The following is a description of a gene set: Mouse Gene Set: chr18B3 species: Mus musculus, and this is the list of marker genes: Kcnn2, Gm31907, Pcdhgb7, Pcdh1, Gm50410, Ythdc2, Pcdhb12, Spink6, Gm31087, Gpr151, Myot, Pcdhgc4, Pou4f3, Rps19-ps13, 1700086O06Rik, Spink11, Gm18371, Grxcr2, Cstdc7, Plac8l1, 4933407I08Rik, Spinkl (serine protease inhibitor, Kazal type-like), Pcdhac2, Gm18652, Mir6979, Kctd16, Ppp2r2b, Sh3rf2, Spink14, Pcdhga6, Arap3, 4930517L18Rik, Gm20162, Pcdhgb4, Pcdhga11 (NCBI Gene Id 93723), Gm18086, Gm4839, Dcp2, Prelid2, BC037039, Pcdhb2, Rnf14, Gm10268, Pcdhgb1, Slc25a2, Gm15337, Gm10540, Marcol, Pcdhb11, Pcdh12, Pcdhga5, Pcdhb13 (protocadherin beta 13), Gm6663, 4930588A03Rik, Gm94, Gm4013, Dpysl3, Gm31205, Gm15335 (predicted gene 15335), Pcdhb17 (protocadherin beta 17), Pcdhb20, Gm41715, Gm23205, Pcdhb6, Spink5, Gm3631, Rps19-ps4, 9630014M24Rik, Mcc, Gm18530, Nr3c1, Mir6981, Rbm27, Pcdhga10, Scgb3a2, Gm5504, Spry4, Lars1 (leucyl-tRNA synthetase 1), Gm4949, Pcdhgb5, Pcdhb14, Diaph1, Pcdhga7, Yipf5, Ndfip1, Gm29994, Pcdhb10, Gm31706, A930012L18Rik, Gm18529, Pcdhgc3, Pabpc2, Gm41708, Arhgap26, Gm10544, Gm41717, Gm16415, Gm19774, 2010320O07Rik, Tcerg1, Pcdhb21, Gm24401, Stk32a, Pcdhb18, Pcdhga4 (protocadherin gamma subfamily A, 4), Pcdhb15, Pcdhgb6, Gm8242 (NCBI Gene Id 674240), Pcdhb5, Taf7, Pcdhga9, Gm8181, Pcdhb1, Pcdhgb8, Spink12, Fgf1, Pcdhga3 (NCBI Gene Id 93711), Gm30093, Jakmip2, Pcdhb4, Pcdhb7, Pcdhb16, Hdac3, Gm31019, 3222401L13Rik, Pcdhga2, Dele1, Mir6980, Gm8390, Pcdhgb2, Pcdhb22, Pcdhb9, Eif3j2, Pcdhb19, Pcdhga12, Spink1, Pcdhgc5, Pcdhb8, C030004G16Rik, Gm5820, Pcdhb3, Gm10267, Pcdhga1, Gm19100, Gm30961, Npy6r, Rell2, Fchsd1, Gnpda1, Gm3650, Gm8302, Pcdhga8